Given this list of marker genes NF1, NFATC2IP, WDR72, ADGRF2P, ERC1 (NCBI Gene Id 84770), MYEOV, PPP2R2B (NCBI Gene Id 56686), PTCSC1, MGA, AKAP1, DCBLD1, PAX6, YLPM1, SF1 (NCBI Gene Id 7536), ARIH1, SCGB2B2, MDM2 (MDM2 proto-oncogene), NHLH1, LUC7L3, SLC44A5, ANKRD13D, LINC00113, ECPAS, PCNP, AQP11, TTC14, MIR646, WNT3, CIMAP2, COQ9, SLC25A15, SLC22A3, EDN3, SLC52A1, CEP41, MIR30C2, SRY, MAP6, RBM19, RAB30-DT, FIGN, CD200, here is a description of the gene set: Background: The live attenuated vaccine Zostavax was developed to prevent varicella zoster virus (VZV) reactivation that causes herpes zoster (shingles) in older humans. However, the impact of vaccination on the cutaneous response to VZV is not known. Methods: We investigated the response to intradermal VZV antigen challenge before and after Zostavax vaccination in participants > 70 years of age by immunohistological and transcriptomic analyses of skin biopsy specimens collected from the challenge site. Results: Vaccination increased the proportion of VZV-specific CD4+ T cells in the blood and promoted the accumulation of both CD4+ and CD8+ T cells in the skin after VZV antigen challenge. However, Zostavax did not alter the proportion of resident memory T cells (CD4+ and CD8+) or CD4+Foxp3+ regulatory T cells in unchallenged skin. After vaccination, there was increased cutaneous T-cell proliferation at the challenge site and also increased recruitment of T cells from the blood, as indicated by an elevated T-cell migratory gene signature. CD8+ T-cell-associated functional genes were also highly induced in the skin after vaccination. Conclusion: Zostavax vaccination does not alter the abundance of cutaneous resident memory T cells but instead increases the recruitment of VZV-specific T cells from the blood and enhances T-cell activation, particularly cells of the CD8+ subset, in the skin after VZV antigen challenge. Human Gene Set: PATEL_SKIN_OF_BODY_ZOSTAVAX_AGE_70_93YO_VZV_CHALLENGE_3DY_DN from publication Patel NP, Vukmanovic-Stejic M, Suarez-Farinas M, Chambers ES, Sandhu D, Fuentes-Duculan J, Mabbott NA, Rustin MHA, Krueger J, Akbar AN (PMID 30247603) species: Homo sapiens Genes down-regulated in skin of body 3d vs 0hr in adults (70-93) (VZV challenge) after exposure to Zostavax, time point 3D